Given this list of marker genes AKT2, SLC2A4, INSR, RPS6, TBC1D4, IRS1, RPS6KB1, MTOR, here is a description of the gene set: species: Homo sapiens Human Gene Set: WP_INSULIN_SIGNALING_IN_ADIPOCYTES_DIABETIC_CONDITION Insulin signaling in adipocytes (diabetic condition)